The following is a description of a gene set: species: Mus musculus Mouse Gene Set: GOBP_C4_DICARBOXYLATE_TRANSPORT The directed movement of a C4-dicarboxylate into, out of or within a cell, or between cells, by means of some agent such as a transporter or pore. A C4-dicarboxylate is the anion of a dicarboxylic acid that contains four carbon atoms., and this is the list of marker genes: Slc25a11, Slc1a6, Ntsr1, Slc1a2, Slc16a1, Slc25a13, Slc1a5, Ucp2, Prkcd, Lrrc8a, Gfap, Slc12a2, Slc25a12, Lrrc8e, Slc25a22, Slc1a1, Lrrc8c, Lrrc8b, Slc13a3, Slc3a1, Lrrc8d, Abat, Slc13a2, Slc1a3, Slc1a4, Slc13a5, Slc7a13, Slc25a18, Slc25a10